Given this list of marker genes Elmo1, Rasa1, Ptk6, Bcar1, Elmo2, Crk, Pxn, Rac1 (Rac family small GTPase 1), Arhgap35, Kras, Dock1, Hras, Rhoa, here is a description of the gene set: species: Mus musculus PTK6 Regulates RHO GTPases, RAS GTPase and MAP kinases Mouse Gene Set: REACTOME_PTK6_REGULATES_RHO_GTPASES_RAS_GTPASE_AND_MAP_KINASES